Given this list of marker genes ATP6V1B1, MT-TQ, MPI, ETFB, RMND1, CLCN5, CEP290, LRP2, GNAS, KCNJ5, MT-ND4, PMM2, ATP6V0A4, SLC34A1, MT-TF, PHKG2, CPT1A, ALDOB, MT-TN, CNNM2, GCK, NDUFB9, STAT3, FBXL4, NDUFAF6, SLC34A3, CLCNKA, COG6, BSND, PIGA, IVD, UQCC2, MT-CO2, NDUFS4, NDUFS8, NDUFS1, ETFA, MT-CO1, SURF1, NDUFB3, NDUFV2, NDUFA11, NDUFS7, TMEM126B, KCNJ11, MPV17, NDUFB11, SLC7A7, MMUT, MT-ATP8, GATM, PC, NDUFB10, CA2, INS, NDUFA1, FAH, JAG1, MT-ND2, FAM20A, BCS1L, POLRMT, NDUFS3, HNF4A, TAOK1, SLC2A2, CTNS, ABCC8, HNF1B, NDUFAF3, NPHP1, PHKA2, PHKB, NDUFAF8, VPS33B, ATP7B, EHHADH, MT-TW (mitochondrially encoded tRNA-Trp (UGA/G)), KYNU, SLC4A1, SLC12A3, HBB, NADK2, MT-TH, CAD, MT-ND5, MT-TL1, NDUFAF1, CLDN16, NDUFS6, PDX1, TRMT5, SEC61A1, CLCNKB, MT-TS2, RRM2B, MT-ND6, NDUFV1, MT-ND1, GATA3, NDUFAF4, PHEX, NDUFA6, MT-CO3, NDUFAF2, TIMMDC1, FOXRED1, VIPAS39, COA8, NDUFAF5, GALNT3, SLC5A2, EPG5, NDUFS2, OCRL, ETFDH, NUBPL, KCNJ2, MT-ND3, NOTCH2 (notch receptor 2), PEX19, SLC4A4, here is a description of the gene set: Abnormal function of the renal tubule. The basic functional unit of the kidney, the nephron, consists of a renal corpuscle attached to a renal tubule, with roughly 0.8 to 1.5 nephrons per adult kidney. The functions of the renal tubule include reabsorption of water, electrolytes, glucose, and amino acids and secretion of substances such as uric acid. Renal tubular dysfunction studied in species Homo sapiens Human Gene Set: HP_RENAL_TUBULAR_DYSFUNCTION